Given this list of marker genes CYP27A1, DAOA, IRF6, DGCR6, JRK, PPP2R2B (NCBI Gene Id 56686), SNCB, DCDC2, RTN4R, SNCA, CEP85L, PRDM8, CRH, PRNP, TP63, HTRA1, TBX1, FIG4, NR3C1, USP48, DEPDC5, CHRNA2 (NCBI Gene Id 1135), NECTIN1, PPOX, BRAF, DGCR2, COMT, VPS13A, CPOX (coproporphyrinogen oxidase), HTR2A, CHI3L1, MSX1, GABRG2, SLC2A3, HLA-DQB1, TP53, ARSA, SYN2, ATRX, C9orf72, SLC25A13, APOL2, CACNA1H, TBP, JPH3, PLA2G6, IMPA1, PSAP, DCTN1, USP8, FMO3, KCNT1, MTHFR, DRD3, TIMM8A, CSF1R, ECM1, CABP4, ESS2 (NCBI Gene Id 8220), CHRNB2, APOL4, GABRB3, EIF2B1, GBA1, TMEM67, HTT, TRANK1, SPTBN1, DGCR8, HMBS, GABRA1, SLC2A1, CHRNA4 (cholinergic receptor nicotinic alpha 4 subunit), MAN2B1, CDH23, here is a description of the gene set: Disorder of thought content Human Gene Set: HP_DISORDER_OF_THOUGHT_CONTENT studied in species Homo sapiens Thought content disorders are characterized by abnormal beliefs and convictions (that are to be assessed given the culture and personal background of the affected individual).